Given this list of marker genes Slc7a5, Id2, Tpsb2, Th, Impa2, Clic3, Frk, Hspb8, Bag1, Trim29, Tfap2c, Sgk1, Tnnc1, Cav1, Stil, Ckb, Top2a, Fkbp5, Mest, Olfm1, Sord, Cdc20, Snx10, Mdk, S100a9, Aldh3b1, Il6st, Dcxr, Krt13, Slc22a5, Isg20, Igsf1, Gper1, Rps6ka2, Pdzk1, Pcp4, Pkp3, Egr3, Tmprss3, Tpbg, Ptger3, Klk10, Calcr, Nab2, Opn3, Dnajc12 (DnaJ heat shock protein family (Hsp40) member C12), Rbbp8, Fdft1, Gfus, Acox2, Bcl2 (NCBI Gene Id 98734), Hr, Car12, Mocs2, Mettl3 (methyltransferase 3, N6-adenosine-methyltransferase complex catalytic subunit), Car2, Tff3, Slc29a1, Plaat3, Myof, Celsr2, Scarb1, Rabep1, Xbp1, Plac1, Pgr, Abhd2, Scnn1a, Farp1, Zfp36, Dhrs2, Areg, Papss2, Cox6c, Prss23, Large1, Gjb3, Tjp3, Myb, Slc27a2, Chst8, Elovl5, Cxcl12, Ptpn6, Siah2, Lsr, Pdlim3, Cdc6, Ret, Chpt1, Mapt (NCBI Gene Id 17762), Jak1, Sfn, Ppif, Foxc1, Gal, Serpina5, Flnb, Fkbp4, Cxcl14, Batf, Rab31, St14, Ptges, Wfs1, St6galnac2, Unc13b, Scube2, Tob1, Xrcc3, Ugdh, Plk4, Slc2a8, Cdh1, Agr2, Abca3, Plxnb1, Cd9, Tspan13, Itpk1, Anxa9, Tfpi2, Add3, Nxt1, Blvrb, Fos, Dlg5, Rnaseh2a, Ccn5, Lamc2, Btg3, Sult2b1 (sulfotransferase family, cytosolic, 2B, member 1, NCBI Gene Id 545963), Ccnd1, Fabp5, Slc26a2, Slc16a1, Cyp26b1, Arl3 (NCBI Gene Id 56350), Dhcr7, Cacna2d2, Il17rb, Perp, Ccna1, Kcnk5, Dnajc1, Emp2, Gale, Aldh3a2, Aff1, Klk11, Sema3b, Tiam1, Cpe, Ncor2, Pdcd4, Amfr, Sox3, Homer2, Eeig1, Llgl2, Slc1a4, Gla, Hmgcs2, Ass1, Jak2, Dusp2, Hprt1, Tst, Etfb, Ovol2, Krt19, Dynlt3, Rapgefl1, Slc24a3, Klf4, Cd44, Cish, Gins2 (NCBI Gene Id 75682), Atp2b4, Mapk13, Igfbp4, Kif20a, Hspa4l, Fgfr3, Prkar2b (protein kinase, cAMP dependent regulatory, type II beta), Ascl1, Nrip1, Prlr, Ltf, Npy1r, Idh2, Nmu, Tpd52l1, Nherf1, here is a description of the gene set: Mouse Gene Set: HALLMARK_ESTROGEN_RESPONSE_LATE Mouse genes annotated to HALLMARK_ESTROGEN_RESPONSE_LATE based on orthology mappings provided by the Alliance Genome Consortium from publication Howe DG, Blake JA, Bradford YM, Bult CJ, Calvi BR, Engel SR, Kadin JA, Kaufman TC, Kishore R, Laulederkind SJF, Lewis SE, Moxon SAT, Richardson JE, Smith C (PMID 30224793) studied in species Mus musculus